Given this list of marker genes Grb2, Thbs2, Pdgfa, Col5a1, Plg, Src, Pik3r2, Col6a1, Col3a1, Col4a5, Stat5a, Spp1, Hras, Col5a2, Col2a1, Pdgfrb, Rasa1, Ptpn12, Plat, Col9a2, Thbs1, Col4a1, Thbs3, Kras, Pdgfc, Col6a6 (collagen, type VI, alpha 6), Pdgfra, Crkl, Col6a3, Stat3, Col9a1, Thbs4, Pik3ca, Grb7, Nck2, Col4a2, Col6a2 (collagen, type VI, alpha 2), Col9a3, Crk, Rapgef1, Col5a3 (NCBI Gene Id 53867), Nck1, Col4a3, Pik3cb, Furin, Pik3r1, Col6a5, Pdgfd (NCBI Gene Id 71785), Ptpn11, Plcg1, Stat6, Bcar1 (NCBI Gene Id 12927), Sos1, Stat5b, Pdgfb, Col4a4, here is a description of the gene set: Signaling by PDGF Mouse Gene Set: REACTOME_SIGNALING_BY_PDGF studied in species Mus musculus